The following is a description of a gene set: Human Gene Set: GOMF_PROTEOGLYCAN_BINDING species: Homo sapiens Binding to a proteoglycan, any glycoprotein in which the carbohydrate units are glycosaminoglycans., and this is the list of marker genes: SLIT2, TNC, HPSE2, FST, CFH, HRG, PTPRF, COMP, LRP1, SLIT1, HPSE, SEMA5A, NID1, FN1, AZU1, COL2A1, CTSK, COL5A3, PTPRC, PTPRS, APOE, LPL, FBLN7, PLA2G2D, CTSS (cathepsin S), THBS1, SDCBP, ADA2, AGRN, CTSL, CTSB, FCN2, FGF20, APP, ITGA2, COL5A1, GPNMB